The following is a description of a gene set: Triplicates preparations of RNA from day 10 DC's. Experiment is described in Wong et al 2003 Nat. Immunol. species: Homo sapiens Genes up-regulated in dendritic cells: wildtype versus CIITA knockout. from publication Wong AW, Brickey WJ, Taxman DJ, van Deventer HW, Reed W, Gao JX, Zheng P, Liu Y, Li P, Blum JS, McKinnon KP, Ting JP (PMID 12910265) Human Gene Set: GSE557_WT_VS_CIITA_KO_DC_UP, and this is the list of marker genes: ZNF563, YOD1, CPT2, PGLS, RRAGD, TFDP2, SLC25A39, DCTN5, S1PR3, NOPCHAP1, MRPL43, TMEM147, ANGEL2, ITM2B, TRIM45, TSPAN15, FBXW10, RPS27L, PFKM, NEB (NCBI Gene Id 4755), TMED9, SMIM8, TXN2, ASCC2, ZNF414, GPX7, BLCAP, LIAS, NAB1, SLC37A4 (NCBI Gene Id 84965), SELENOF, WDR24, RIDA, TMOD2, TOR3A, CSGALNACT2, COQ2, FIRRE, MRPL44, TCN2, TMEM18, CRACDL, CREBZF, ARFIP2, PA2G4, DDT, RRP36, AKR7A2, KLHL22 (kelch like family member 22), STK16, TBCCD1, SREK1 (splicing regulatory glutamic acid and lysine rich protein 1), FYCO1, VARS2, BST1, SOCS5, IL16, LYNX1, IMP3, GNE, LGALS9B, C3orf33, SMCO3, ZNF329, NDUFB3, NUDT6, RCN1, OIP5, SREK1IP1, H2BC13, TMEM191C, STARD3, DPP4, SLC46A3, PCTP, ATP13A1, PTGR2, EID1, MTCP1, OBI1, ACSS1, MATK, MFHAS1, UPF3B, NDUFAF1, ANKRD49, CCDC28A, HYI, NAE1, ABCE1, COLGALT1, COA3, SOCS6, HMG20A, PRXL2A, NTPCR, ABHD17A, TIRAP, CTNNA1, PTPRS, MAP7, REEP5, ORMDL2, NUS1 (NUS1 dehydrodolichyl diphosphate synthase subunit), DGCR8, SFXN5, COMMD3, RTP4, POGLUT1, SLC29A3, LCAT, PCBP3, SRSF1, TLR7, IKBIP, SERPINE2, SLC35A1, AS3MT, RRBP1, SMYD2, FAM111A, IL12A, POLDIP2 (NCBI Gene Id 26073), PARD6G, MGST2 (NCBI Gene Id 4258), SLC25A11 (NCBI Gene Id 8402), COX18, SLC22A3, NUDT12, SLC20A2, COASY, STARD5, RAP1GAP, ADCY7, STRN4, CDC26, EXTL2, ACAP1, TRMT1, HINT2, ZNF708, STOM, LGALS3BP, ST3GAL6, TEDC2, NUDT19, MTG2 (mitochondrial ribosome associated GTPase 2), IFI27, RABL2A, NUDT16, ABRAXAS1, STARD6, LTK, NAT10, FANCA, NDST1, SCEL, SEPTIN6, SEC61A2, ELL3, PHPT1, ZNF43, ARAF (A-Raf proto-oncogene, serine/threonine kinase), CACNB4, ZDHHC14, DYNC2I1, TTC28 (tetratricopeptide repeat domain 28), TMED6, FAM168A, ZMYND11, ZNF790, POLR1E, MYBBP1A, WDR83 (WD repeat domain 83), L2HGDH, COPG2, DDX60, COL20A1, IFT140, NUP43, RPP14, MTG1 (NCBI Gene Id 92170), PDLIM2, PSMC3IP, APH1B, MGST1, C17orf75, TSN, NOXRED1, TNFRSF13B, WDR12, SUFU, PER3, TIMM8B, COMMD5, PTPRCAP, MPHOSPH9, ZNF235, OAS2, GSTZ1